Given this list of marker genes ARHGEF11, MICU2, CASTOR3P, NDUFAF8, UPP1, SNORA13, CBFA2T2, RNPS1, SLC25A6, CMC2, NXF1, IFT52, BFSP2, UQCRH, SGMS1, SLC38A2-AS1, C7orf25, SUPT7L, ADRM1, OXR1, ANP32E, GBA1, RNY3, SEC61B, STEEP1, CNN2, NDUFA11, MTERF3, NUTM1, PURPL, KCTD18, ID2-AS1, UQCC6, PDE2A-AS1, QSER1, RRM2B, SSR4P1, ELMO2, STK35, LINC00544 (NCBI Gene Id 440131), CIDECP1, SLC25A45, TWSG1, FBXO8, CDK12, ATP13A1, HSF4, TRIB3 (NCBI Gene Id 57761), MIR548K, NOP10, MST1P2, ST7-OT4, TAX1BP1, BAG5, ZNF76, DIP2C (disco interacting protein 2 homolog C), TWSG1-DT (NCBI Gene Id 102724397), SNHG25, EFNA4-EFNA3, MYNN, RFX2, PCNX2, PIK3CB (phosphatidylinositol-4,5-bisphosphate 3-kinase catalytic subunit beta), HEMK1, TEPSIN, NOTUM, LEO1, WDTC1-DT, RAD51AP1, GRHL3 (grainyhead like transcription factor 3), TNPO1, B4GAT1, SEC22B, CEBPA-DT, AKAP8L, PIM3, C2orf69, BRWD1, SEMA7A (NCBI Gene Id 8482), NAA50, POC1B-GALNT4, VWA7, ENSG00000268129, ATR, ZC3H3, SIRT1, HIF1A, EIF2AK3-DT, UBE2V1P4, C9, ZNF148, PLXDC1 (NCBI Gene Id 57125), RN7SL1, IL21R, CFLAR, ASAH1, DHPS, UBIAD1, H1-10, WWC2-AS1 (NCBI Gene Id 101928734), MOB3A, VARS1, SPATA4, TPGS2, ENSG00000187951, RNU6-1013P, STK25, ARHGAP17, SPG7 (SPG7 matrix AAA peptidase subunit, paraplegin), ABHD16A, PMVK, ENSG00000275765, VTI1A, BARHL1, NXT2, AHDC1, CD8A, ACAP3, SNHG29, ANKRD31, EIF3F (eukaryotic translation initiation factor 3 subunit F), MIR3613, RNASEK-C17orf49, NOTCH2NLA, BCL6, PIEZO1, KIF26B, MYO15B, MIR3189, CALM3, CELF1, LTBP3, IFT27, LPCAT3, SLC35F2, GSDMD, DCTN4, TUBB2A, ZC2HC1C, MTBP, HIP1, MGAT1, DCUN1D2, ARID5A, CHST12, KLHDC10, CTNNB1, ELF1, TEX2, TRIM32, MAPK6, ERCC1, PLEKHG5, ITFG1-AS1, PYGO2-AS1, PIH1D2, LZTFL1, ZNF609, SSH1, PEX13, RGS1, DNAH14, FBXO44, EIF2S3, ARPC4-TTLL3, TYW5, NUDT3, SLC9A6, RPL7AP60, ZNF689, IQUB, CBY1, GAREM1, ANKRD36, KPTN, ARL1, CYS1, GORASP1, FLCN, PSMD3, TMCC1-DT, IL6R-AS1, TBCK, NR1D2, C19orf53, AHCTF1, ABHD2, WASF2, STIM2, PTCD1, PXK, MOB4, MRPL13, RAD9A, RLIM, FBXL13, RFX1, ENSG00000254006, STIM2-AS1, TFDP1, FKBP5, SNHG17, LSG1, MIR548AW, NYAP1, POP4, CENPN, ZNF77, TSKU, MTCH1, BRIX1, TK2, HMGB1, EXOC3L1, PKN3, CA11, MADD, PHLPP2, BTG2-DT, SLC25A46, RRAS2, AIMP1, MPLKIP (M-phase specific PLK1 interacting protein), ZNF891, SF3A3, PPM1A, EARS2, RN7SKP127, DCLRE1A, COMMD6, SYNE2, EI24, TLR5, SDF4, MED13, TEX10 (NCBI Gene Id 54881), PPFIA3, AP3M2, NUP153-AS1 (NCBI Gene Id 105374952), LGALS3BP, RNF213 (ring finger protein 213), NECAB3, HOOK2, MIR4435-2HG, GNB1-DT, PIGZ, ENSG00000255367, INAVA, FRG1-DT, TMEM121, RELT, CPEB4, ZC2HC1A, TMA16, EGLN3, RPL41, THUMPD3-AS1, XKR9, CD55, ZNF165, SNORA26, LRRFIP1P1, CDON, IMMP1LP1, TNFRSF1B, NMUR1, ATRIP, DOC2A, ZFP64, ARF4P2, CENPJ, CENPS-CORT, THAP4, XYLB, TCHP (trichoplein keratin filament binding), NBPF15 (NCBI Gene Id 728936), TPRN, FLI1, ZNF513, NDUFS3, KCNT1, HSD17B14 (hydroxysteroid 17-beta dehydrogenase 14), OSBPL9, VPS52, FAM241B, PHF19, GPNMB, HDAC2, PRMT3, RIN3, RRAGC, CGB7, GMDS, DNM2, IL13RA1, BAZ1B, PIM1, LINC02168, RBBP5, CDKL3, DNAAF10, LINC02918, MAML3, PSIP1 (PC4 and SRSF1 interacting protein 1), TPM1, NBPF25P, LRP12, C19orf25, TMPO-AS1, ARMH3, IL9R, MYL12-AS1, JMY (junction mediating and regulatory protein, p53 cofactor), TRIM13, KLF13, TRPC4AP, GCNT1, CAMK2D, PDP1, SMYD2 (SET and MYND domain containing 2), ISLR2, C6orf62, WDR36, NBPF9, PAXIP1, POGK, CEP128, RBM48, RUSC2, VNN2, PAFAH1B1, PRPSAP1, ERI3, AP4M1, PI4KA, PPEF1, RHBDF2, SMARCD2, MIR4674, TRIP13, SLCO4A1-AS2, C2orf42, SEC24B, MACROH2A1, MAP3K4, TPBG, MEF2A, RNF32, TJP3, TFAP2A, ACTR3, C12orf42, ENSG00000267448, PRKCI, SUMO3, FBXO34-AS1, PET100, CPLANE2, ANKRD16 (NCBI Gene Id 54522), PPP1R9B, SARAF, LINC00431, TMBIM1, DUSP16, REXO4, BAIAP2L1, CNOT10, TMEM91, CCT3, SCRIB, MIR4645, SPATS2, SNORD48, ZNF786, RPL35A, SPATA17, RPL21, RCC1L, CEP44, TRGV6, TNIP2, LINC01348, TMCC1, LINC02363, ANKRD46, ARSB, HAUS8 (HAUS augmin like complex subunit 8), ZNF580, ST7, EIF4A2, SURF4, FRG1, FABP5P5, ALG9-IT1, CPT1B (carnitine palmitoyltransferase 1B), DANCR, KDM7A-DT, HYCC2, AP2A2 (adaptor related protein complex 2 subunit alpha 2), CLN6, ARHGAP45, BCL2L13, NEMP2, UBE2I (NCBI Gene Id 7329), TNRC6A, DESI1, NIF3L1, MSL3 (MSL complex subunit 3), EPS15, ZNF639, TET3, NSG2, BHLHE40-AS1, SAMD11, NECTIN1-DT, SMARCAD1-DT, ARHGAP22, RNU12, NR2F6, CDK5R1, ELK4, TRIM44, ARID5B, XXYLT1, LRPPRC, GZF1, FAM117A, WARS2-AS1, GPR132, SPIRE2, ATL1, ZFAND3-DT, IVD, DLC1, TARS3, IKZF4, CCDC85A, VPS51, MRPS23, CLPP, MLEC, ODF2, BBC3, BAZ2A, PPM1H, RAP2A, DPY19L1, ATP8A1, PARP1 (NCBI Gene Id 142), ZNF775, ATG101, PAXBP1, ADAM10, SRF, CENPK, OXR1-AS1, ANKRD12, LINC00963, NOTCH1, MIR29B2CHG, PTMA, CFAP97, RNF11, KBTBD2, C11orf68, MIR7-3HG, ZNF697, SPCS2, PTCD3, C6orf226, ATG13, ADNP, LINC01521, MTPAP, CPSF2, ITIH1, ENSG00000275635, COX20P2, SAE1, RAD1, RSAD1, EXOC2, HERPUD2-AS1, ANKMY2 (NCBI Gene Id 96008), DHRSX, CHMP6, LMNB2, CRACR2B, SEC31A, SLC29A1, FOXK2, CSNK2A1, ENO3, FBXO24, SEMA6A, POLR2A, PPP6C, CENPF, PRKCH, PWWP2A, ATF6, RHBDF1, ISG20, MRPL54, CD37, HSDL1, CGB2, NUP85, PEX1, MIPOL1, SMAD3, TMEM198, NDUFA5P11, PPIL3, KBTBD4, ZFX-AS1, CCDC97, MAN2A1, TLCD2, CDC45, ROBO1, ADAP2 (ArfGAP with dual PH domains 2), STAG3, IDUA, NR1H3, BAMBI, CLN3, MAPKAPK5-AS1, ZXDC, RNF135, CFLAR-AS1, CTTNBP2, FAM184A, PPP3R1, MARCHF9, TBC1D8, TRIM11, PXT1, SNHG7, LMNA, LNCOC1, ACOT8, PRMT5-DT, ILKAP, MCM9, H2AC13, CUTA, FRYL, VPS13B-DT, SIPA1L1, SLC9A1, VLDLR-AS1, ATF7IP2, PARAIL, ZNF131, SREK1IP1, KDM5A, FLT3LG, LINC01920 (NCBI Gene Id 101929260), FAM177A1 (NCBI Gene Id 283635), PCSK7, SART3, LY9, KDM5C, YJU2B, SYT7, DDX5, PAXIP1-DT, CRLF2, YPEL1, RNU6-841P, LUC7L, TRG-AS1, PTPN18, STKLD1, TRAF3IP2-AS1, IQCG, TFEB, PNO1, RPL23AP82, NAPEPLD, GBP4, MAP3K20, WASHC2C, CEP95, REPIN1, SUGCT, XPC-AS1, WNT10A (Wnt family member 10A), PRDM4, TPT1, LRP6, JAG2, SETD1A, CDC25B, FUS, RIN1, SLC2A5, RNFT1-DT, TMT1B, ANKZF1, DNAJB1, NOC4L, CAND1, SREBF1, IRF2BP2 (NCBI Gene Id 359948), RPRD1B (NCBI Gene Id 58537), PMEL, SLC1A4, UBFD1 (ubiquitin family domain containing 1), ANKLE2, DCBLD2 (discoidin, CUB and LCCL domain containing 2), LINC01962, PLEKHB2, SRRM1, TNFRSF13C, PPM1F, FSD2, BBLN, NDUFB3, SLC25A4, IBA57-DT, KEAP1, LINC01003, FAM53A, ARHGAP11B-DT, ARPP19, TRAPPC5, FBRS, PPP5D1P, FOXA1, RNF168, TPT1-AS1, MAOA, PKIA, CHMP1B, SF3A2, DCTD, WASL, HABP4, EMC4, MICOS10-NBL1, PUM3, TRAM2-AS1, DGKQ, GABARAP, TRAF2, LDC1P, PSMC3IP, DHX30, TSR3, TTN-AS1, PCBP2, PURB, PEAK1, TFRC, CCT5, ENSG00000232732 (NCBI Gene Id 101927687), STAM2, DNPH1, HSPB1, LINC01409, RAI1, VMP1, VCP, PRKAB2, CELF3, RPS15AP29, FAM111A, TMEM60, JRK, ABCA6, RFX7, FSTL3, SRA1, PLLP, RBPJ, EMC10, LINC00881, HNRNPF, ATG4B, VSIG10L, RNU2-17P, TADA3, RANBP9, PRR3P1, C2orf88 (NCBI Gene Id 84281), SNRPE, SLC26A11, JMJD1C, B4GAT1-DT (NCBI Gene Id 102724064), LINC01624, NLK, ZNF815P, TMEM259, TPTEP1, ZNF335 (zinc finger protein 335), NUP54, JPX, TMCO3, KCNC3, PSMB9, TSHZ1, GNA13, LINC02593, DOHH, LMBR1L, BLCAP, RNVU1-15, QRICH1, LINC00620, WDR83OS, SELENOS, BCAP29, SUPV3L1, DNAJB6, ARNT, ENSG00000265222, ZCCHC24, RSRC1, TECPR1, DPP9, IPO9-AS1, GNL3L, ABCB10, MEX3B, OMA1, BRD9, KCNB1, PCOLCE-AS1, RNU5D-1, ERI2, BZW2, EIF3B, CCAR2, POC1B, TTLL7, TOP2B, SKIL, LITATS1, PPP6R3, ZNF892, LL22NC03-63E9.3, INTU, MAPKAPK5, COX5A, CFAP410, TANGO2, BOD1L1, ATP6V1FP1, EPDR1, MTIF2, SH2B1, CCDC47, KMT2A, REXO1, ZNF836, FXR2, ASIC4, NCLN, ZNF10, WWOX, PABPN1, PIGP, CEBPA, FRA10AC1, NPTXR, KATNBL1, RNA5SP493, DEPDC1 (DEP domain containing 1), SHOX2, CD69, CCNE1, CBL, ADAM18, H3-3A-DT, GORASP2, POLR2J3, MRTFA, IVNS1ABP, TCF4, CXXC5, DAPK2, POLR2J4, SLC12A8, POLR3E, TRIM69, C1orf159, UQCRC2, PTEN, WDR6, LYPLAL1, ST6GAL1, ZMPSTE24, VARS2, MYO16, PIK3R3, AMN1, CACNA1A, ASH1L, NAB2, RPS3A (NCBI Gene Id 6189), HSPE1-MOB4, KCTD1 (NCBI Gene Id 284252), LRP3, ITGA9-AS1, TOR1AIP1, LINC00511, ISY1-RAB43, GALNT2, LIMD1-AS1, GDF15, TARS2, HMBOX1, FCHSD2, PNN, MLF1, POGZ, NSUN4, RNA5SP152, IL9RP3, NEK6, ENSG00000266313, MYO9A, HMBS, ENSG00000259755, SESN3, UST-AS2, TMEM219, NUFIP1, ANKRD9, GOLGA8A, FBXO25, TCERG1, UBE2Z, ARRDC3-AS1, KAT5, ATMIN, LPGAT1-AS1, MDC1, MIA2-AS1, ATP2C1, CXCR3, DGAT2-DT, RPL22, DDHD2, PPWD1, CENPS, TNFRSF17, LTA4H, DCAF5, DHTKD1, MIS12, SCAF8, BMF, DYRK3-AS1, DDX51, PCSK9, CMSS1, SELENOW, MRPL38, ATF6-DT, FRMD6, LINC01480, ADPRS, EPS8L2, IL16, DNAJB2, DAP3, RCAN1, CCDC59, SAR1B, SS18, SMG6, CCDC88A, PUS10, TRIM7-AS2, HINT3, IFI44L, RNF217, NDUFAF1, UCHL3, PCAT7, USP42, LPGAT1, USF1, VTRNA1-2, LINC02901, MAIP1, ZMAT1, AP2S1, MAPKAPK3, TRIB1, H2BC13, BICDL1, CHAF1A, INSIG1-DT, GLI1, SIGLEC5, KCNH1, C11orf24, USPL1, ZNF408, MICAL1, PCAT6, MDM2, PRAME, ARHGEF40, RPS26, HNRNPA2B1, TNFSF14, DYRK1A, HSPD1, BUB1, PATZ1, LSR, FNBP1P1, DNAJC6, RALGDS, PIP5K1B, CSTF2T, B3GALT4, RCE1, ZNF654, TIGD5, TG, PTPN11P3, NDUFS7, ZNF141, STX11, ZBTB20, SLC38A2, MAP4K4, ICMT-DT (NCBI Gene Id 148645), PTPDC1, GTF2H4, APBB1, C17orf75, ELL2, PIGT, NTMT1, TTC22, ARMC10, EFCAB7, GNB2, TASL, FBXO33, H2AZ1-DT, SNX8, CLEC17A (NCBI Gene Id 388512), ARL2, MAST1, PARVB, GDNF-AS1, HS6ST1, VEZT, KAT14, ACOXL-AS1, CD82, CROCCP2, CDC42BPA, RNFT2, COA1, CHASERR, SETD5, GET3, NRAV, MBOAT2, MYL12B, TCAM1P, DUT, PLEC, RNF214, GCGR, PIK3IP1, CFAP69P1, ALDH4A1, SERPINB1, CEP164, SEC16A, CCDC85C, ARFGAP1, ATF7, EEF1D, ELOVL1, DUSP1, ACYP1, CKB, SLC2A9, EIF4ENIF1, B3GALT6, ZFYVE9, PNPLA7, CREBRF, MACORIS, CENPP, TRGVB, PPP2R3B, SLC35E2B, FAM110A, ENSG00000261335, GPALPP1, GPR18, KCTD10, RN7SKP165, CREB3L3, NR2C2 (nuclear receptor subfamily 2 group C member 2), EP400, LINC00609, EPCIP-AS1, PPP1CA, ZFR, LIN7B, ASTN2, ACKR3, ANKRD11, MIR638, PRDX2, MANF, UTP18, OASL, STAG3L3 (STAG3 cohesin complex component like 3 (pseudogene)), KLHDC2, TAF15 (TATA-box binding protein associated factor 15), MADCAM1, PDPR2P, CORO1A, RAB3A, GPR146, MIR4479, ERVK13-1, TENT2, RPS27L, TRIP10, LTBP4, KCNAB2, ASPSCR1, BCKDK, KIF9, TMEM117 (NCBI Gene Id 84216), CLIC5, LAMP1, GNB1, SPOPL, PLXNB2, TENT4A, TRIP4, LRP2BP, IRAG2, PHRF1, ITSN2 (intersectin 2), TMEM37, MAP2K3, CSNK1G2, ZMPSTE24-DT, SLC25A25, TCAF1, EXOSC10, ZNF395 (NCBI Gene Id 55893), SGPL1, LINC00973, INTS9, DVL1, DRC3, RGS5 (NCBI Gene Id 8490), ACP2, YJU2, YY1AP1, CHST11, PRDM10, STPG1, AUTS2, INPP5A, THEM6, PDCD1, RCL1, CDKN2C, AATBC, DHRS12, HEXIM1, REV3L, SPRED2, VDAC1, RPS7, NAIF1, CFL1, UFSP2, NACC1, ALG8, CDIP1, FERRY3, YPEL5, TNFRSF10B, PFDN4, LRRC41, TBC1D2, GCLM, ZNRF1, RNU5B-1, UBTF, DIS3L, HIGD1AP5, SEPTIN2, ALMS1, RPL10A, RMND5A, KAT6B, LYRM1 (LYR motif containing 1), YWHABP2, RPL27 (NCBI Gene Id 6155), MND1P1, KATNB1, CTCF, PKNOX1, CDIPTOSP (NCBI Gene Id 440356), FCHO1, FRG1HP, JPT2, CLTB, MAN2A1-DT, FBH1, ELOVL6, SNORD49B, VTRNA1-1, MLF1-DT, RNF185, BZW1, NALT1, DDX59, TCF7, CPLX1, ILF3-DT, TMEM156, CHSY1, EPB41L4A-AS1, NAT10, TMEM260, PSMC3, ANG (NCBI Gene Id 283), ZNF212, MNX1-AS1, ETV2, PRC1, UBE2V2 (ubiquitin conjugating enzyme E2 V2), LYPLAL1-DT, RAB11FIP3, ZSWIM1, NHLRC2, TSKU-AS1, SPTSSA, MRPS7, H2AC14, ALG9, PPM1L-DT, TXNIP, RHOBTB3, DNAAF1, KLHDC8B, PYGO2, MEF2C, RNU1-19P, BTG2, STT3A (STT3 oligosaccharyltransferase complex catalytic subunit A), EFNA5, H4C11, ST20, TLR1, ENSG00000235978, MAF1, MIR5091, FAF1 (NCBI Gene Id 112268262), ALG10B, DDX42, MRNIP-DT, NUF2, FKBP8, TSACC, CALM2, MAD1L1, METTL25, LNCRNA-IUR, LANCL2, RAB39A, DMGDH, RPL12P28, SLC7A5P2, POLR1G, H4C5, ATP8A1-DT, ARPC4, PSTK, NKILA, CCNL1, GMDS-DT, LINC02174, ZMIZ2, RFLNA, MICOS10, FBXO34, RECQL5, MST1R, NEAT1, PELI3, PSMC2, CCDC7, TBC1D17, SLC2A8, GATAD2A, CTTN, GPR89A, PHF24, ACHE, KIAA1328, VPS37B, VTRNA1-3, PAK1IP1, PGD, UBE2A, NKAIN4, SLK, NECTIN1, SNX19, SPRING1, PADI1, ZFAND3, DNASE1, TCP11L2, UBL4A, NSMCE3, SACM1L, AHSA2P, UROS (uroporphyrinogen III synthase), NUBP1, SP2, RAI14, TH2LCRR, LGALS14, RARA, BUD13-DT, MRPL46, ZSWIM3, SPIN2B, ATP5F1B, CREG1, TSC22D3, POM121, UBE2B, TNFAIP8L1, LSP1, OBSCN-AS1, PUSL1, CBX3, RNA5SP324, RAB33A, RNVU1-26, VPS13B, AJUBA, ORAI1, C8orf82, C6orf52, AKR1B15, MBTD1, PDXDC1, TEAD1, PLEKHA1, LIN9, RERE, ARID2, H4C8, SCAND3, HTR5A, SYN1, DCUN1D3, NAPA-AS1, SPPL3, GNPTG, ZNF521, COPS8, CFAP20, NDRG1, PRDM1, MUC20-OT1, ADGRV1, ENSG00000232995, TEX9, ILF3, TCF3, LMBR1, NDUFV2-AS1, SCAT1, PTOV1, CUL1, ULK4, FBXW7, FAM168B, LINC02086, CCDC144BP, PLEKHG2, RHBDD3 (rhomboid domain containing 3), MTMR14, COPS8-DT (NCBI Gene Id 401037), RNF103-CHMP3, MTCL2, AP3B2, MIR4453HG, PTK2, ATG9A, RIPK2, MTMR12, MNT, HPN, ZNF391, LRRC71, ADORA2A, ATP5F1D (ATP synthase F1 subunit delta), TMC7, CPNE2 (copine 2), ZNF300 (zinc finger protein 300), CFAP221, FGD5-AS1, NFAT5, HDAC5, GPR108, APBA3 (NCBI Gene Id 9546), INSIG1, ZER1, NDUFB1, LMAN2, RELN, DYNLL1, HNRNPC, MYL11, HMGN2, FGD6, PLEKHG4, MPDZ, TIMM13, ENSG00000258623, PCTP, PAK1, PRMT5, LINC02028, RHPN2, EWSR1, TBC1D10B, EFNA4, ENSG00000257989, PITX1, SLX4, FAAP20, POMZP3, PDE2A, FAM21FP (NCBI Gene Id 648708), MIR3677HG, TRGV3, EVI5L, RUNX1, DCTN6-DT, SDHAP4, TBC1D4, GPAT4, NFKBIA, PARD6B, MAT2A, PPP1R37, FBXL16, MCM7 (NCBI Gene Id 4176), ADCY7, SRCIN1, PLCL2-AS1, TMEM87B, STK10, ASB6, SMURF2, BUD13, DNM1, ZBTB45 (NCBI Gene Id 84878), ARTN, RTTN, CHMP7, LINC00475, HIVEP3, ENSG00000266088 (NCBI Gene Id 105371773), SPHK1, SAMD4B, OTUD4, KRBA1, TNNT1, DNAAF3, PPP1R13L, KTN1-AS1, RNU4ATAC, NDUFAB1, PIK3AP1, SGMS1-AS1, OCEL1, DGAT2, RNASE4, DIXDC1, RWDD1, IPO9, UBA1, KRAS, DDX18, UBE3B, RNFT1, RPL37, KDM1A, RRAGB, GSTP1, PER3, GAB1, MIS18BP1, UIMC1, WASH3P, DENND4A, CFAP96, TAP1, ZFX, SAAL1, SLC35C2, LINC00938, BLTP3A, EXOC7, MTO1, BRD3OS, C3orf86P, RHBDL3, PSCA (prostate stem cell antigen), CISH, GGA3 (golgi associated, gamma adaptin ear containing, ARF binding protein 3), TRMT112, KDM4B, AHCYL2, THAP9-AS1, RTN4R, GTF2A1-AS1, GPAT4-AS1, BICD1, ICMT, TACSTD2, CYP17A1, ELL3, CBFB, THADA, FER1L4, SP1, ZNF778, VPS37D, PPM1L, RNU6-9, MCRIP2, GOLGA3, UTP3, ARL6IP5, SGO2, ENSG00000254718, WBP4, INTS5, CREM, TNFAIP3, RRAGC-DT, COA8, KMT5B, ZKSCAN2, RNU6-230P, DAO, RPS24, KHSRP, EPS15-AS1 (NCBI Gene Id 105378720), PPIA, LNC-LBCS (NCBI Gene Id 115561815), DISP3, KTN1, LARP4, SEC22A, ID2 (NCBI Gene Id 3398), RAB6A, SMARCE1, SNX12 (sorting nexin 12), DAB1, USP5, OGT, VMAC, ITGB7, DCP1B, BIRC3, ZC3H12A, SS18L1, RSL24D1P11, FCSK (fucose kinase), RNF166, RNU5B-4P, MORN1, LINC01629, RMI2, INTS10, MICAL3, VSIG10L-AS1, PHTF2, PCED1B, ATF7-NPFF, CYP51A1-AS1, MIR5194, PSMA7, SMAD3-DT, CORO6, DCUN1D4, TAP2, IL1R1, PARP12, SLC35E2A, PSEN2, WDR83, SAYSD1, DDX11L10, METTL26, IQCD, PANK3, WRNIP1, LINC02773, ARHGEF10, PTDSS1, CDK4, MIR1208, XPO7, NUMB, SHARPIN, TSC1, CWC27, TSNARE1, ZNF710, H4C4, NRF1, MIR378D2HG, PIP5KL1, ATXN2L, ZDHHC6, ZNF687, WASL-DT, SOCS2, SIGLEC14, AJUBA-DT, AQP10, TMEM160, VAT1, DLGAP1-AS1, NSMAF, KLK2, NEURL2, CNOT11, HNRNPUL1, CDKAL1, RNA5SP200, ZBTB4, NUTF2, FAM156A, IGHM, SLC25A22, RNA5SP168, GDI1, FGFR2 (NCBI Gene Id 2263), MAP7-AS1, SH3BP5, RAB30, LINC02984, MTG1 (mitochondrial ribosome associated GTPase 1), MIR6821, DNMT1, HMGN1, ZC3H6 (NCBI Gene Id 376940), XRRA1, H2AZ2-DT, SEPHS1, GIPC1, DUT-AS1, UBB, CYP20A1, UBALD2, EPC2, SEPTIN6, ATPSCKMT, OLA1, CPNE2-DT, GABPB2, ATP6V1A, PICK1, RNVU1-31, CTU2 (NCBI Gene Id 348180), POR, NKAPD1, MAPK6-DT, LYL1, MYL12A, TBL3, GPBP1, RNU5E-4P, PDXDC2P, CCNB3, DLST, VDAC2, IGF1R, H2BC14, FSD1L, FHIP2B, ZBTB21, ZNF581, RBM38, SMARCA2, RAB11A, TBC1D24 (TBC1 domain family member 24), TRAPPC10, G3BP1, APOL4, AGRN, ZDHHC2, MIR4449, ARMH4, SHB, ARHGAP1, FAM78A, CWF19L1, IBA57, C17orf99, CDC42SE1 (CDC42 small effector 1), MRPS11, GFI1B, KIF2A, CHPF, LNCTSI, EIF2D, WDTC1, CLASP1-AS1, SMG8 (SMG8 nonsense mediated mRNA decay factor), ANKRA2, NEU4, ABCC1, SAXO5, WSCD2, EIF4H, H2AX, ARID1A, DRAP1, GTF2A1, ARL5B, ENAM, HIBADH, RHOC, NDST2, PPP3CA, CTSA, C21orf91 (chromosome 21 open reading frame 91), PIP4K2B, XAB2, UTP15 (NCBI Gene Id 84135), KDM3A, RAB4B-EGLN2 (RAB4B-EGLN2 readthrough (NMD candidate)), MICOS10-DT, PCOLCE, H2AZ2, DHRS13, ARRDC3, MIR7155, ZNF821, SLC25A42, ARAF, SMC3, MIR4487, KIF13A, AK2, CBLN1, LINC01623, NFE2, RNF216, PMS2, C19orf48P, KANSL3, SMARCAD1, C3orf33, TOR1B, SMAD6, TALDO1, SPRYD4, CCNI, AKT1S1, LINC03072, PDXDC2P-NPIPB14P (NCBI Gene Id 731999), GRSF1, UACA, ALG2, MAPK8IP3, SNORA50C, NAV2, REV1, MNX1, RGS3, NUDT9, IQCH (NCBI Gene Id 64799), ATAD2, HLA-DMB, LINC02051, SBNO1, PRDX5, MRPL44 (mitochondrial ribosomal protein L44), THAP9, SEC24B-AS1, SNAP29, NFIC, PPFIBP2, RNF38, GPATCH2, PFKFB3, ENSG00000236846, NFATC1, MAPK1, RHOT2, COQ2, ZNF223, CENPN-AS1, KLF11, GARIN5A, CCNT2, NDC1, IPO13 (importin 13), SIRT3, IL4I1, LAIR1, AAGAB, ZFP3-DT, NSUN6, ADARB1 (adenosine deaminase RNA specific B1), MSL3-DT, CLCNKB (NCBI Gene Id 1188), ZNF687-AS1, UGCG, MTHFD1L, USP22, KCTD20, DYRK3, GASAL1 (NCBI Gene Id 401472), HERPUD2, ZNF282, TNC, TGM5, TAMALIN, UBE2O, MED16, EXOSC3, PDE4A, WDFY4, RBM6, RHOH, PTPA, SET, SNRNP35, CSMD1, RNU6-2 (NCBI Gene Id 103625684), LINC00240, ZNF143, AP1G1, APBA2, PIPOX, CRADD, APOBEC3D, ARID1B, PCBD2, MIR3928, DRAM1, NINJ2-AS1, MEIS2, KLLN, TCEAL1, ASAH1-AS1, DPM1, NOL8, CHCHD2P1, SMAD7, CD24, LIN54, NCOA3, EED, BRPF1, MIA2, TOM1L2, FLAD1, RPS14, NMT2, ADSS1, HARBI1, PICALM, RAB4B, GNG4, UFD1, PIK3R1 (NCBI Gene Id 5295), MAP4K5, NEMP1, CDIPT, MIR1302-3, RCOR1, RAB28, RDX, RNASEK, INO80, PRELID3A, SRSF9, FCER2, WRAP53, CLUAP1, TARDBP, CRK, H4C3, MIR4757, EXTL3, GLCCI1, RNU5A-1, ESYT1, ANKRD37, USP14, MRPL39, SRPK2, MYADM, RN7SL784P, GCN1, MIR6815, ATP6V0C, HMGA1, MGRN1, SIK2, TOP2A, AIMP2, TRAM2, FAM222A, SPIDR, RPS6KA1, CGGBP1, ZNF143-AS1, ZNF664, ISY1, KCNH1-IT1 (NCBI Gene Id 100874296), LRCH4, MEMO1, GAB2, HDGFL2, CCDC77, PSMD13, SNHG32, CEACAM7, KRT8, TRMT1, SLC4A1AP, NSD2, ARHGEF16, KLHL18, ASF1A, CXXC4-AS1, INTS1, LINC02404, PHPT1, PMEPA1, S100A11, SPOPL-DT, KDM7A, PRDM10-DT, SRFBP1, PET117, CBX4, EIF2AK3, SYT9-AS1, CDCA2, USP9X, SAXO3, ZNF84-DT, CCDC6, GPR107, TLCD4, ANKRD13A, DAB2, AKIRIN1, DDIT4, KCTD9, PRMT1, HEYL, CDCA3, HECW2, AMER1, HYAL2, ZNF84, TMEM250, FAM227A, CACNA1C-IT1, GGA2, SEPTIN5, ANKRD36C, TBC1D13 (NCBI Gene Id 54662), HDAC2-AS2, CTCF-DT, RPS18, ZNF354A, DCTN6, GRHL3-AS1, CYP51A1, ZNF488, NR6A1, CCDC92, MCM5, CCDC107, HDAC6, NFKB2, MARCHF2, DERL2, EGR2, PLEKHG1, PPFIA1, PLEKHJ1, CPSF4 (NCBI Gene Id 10898), PDXK, TLCD4-RWDD3, VDR, LINC01347, RER1, MYO9B, LDLRAD4, TIA1, COPS4, KLHDC9, POLR1A, SNORD104, NEMP2-DT, ENSG00000233230, TSC22D1, TMEM243, PDK4-AS1, GET4, MIR7-3, PLCG1, RN7SKP175, SMG1P3, U2SURP, KANSL1, AKNA, LSM12, WIPF1, CENPE, ARL2-SNX15, AMZ2P1, SLC44A1, RMRP, CDC73, LINC02642, RPS29, DNAJC2, TMEM248, AK4 (adenylate kinase 4), ESCO1, MTX2, RNF103, H4C12, RAB5B, CYTH2, BCCIP, OLFM2, SFSWAP, SNX25, ZCCHC2, ENSG00000207002, MOCS3, CCDC88B, MDK, ZNF839, ANPEP, MAP2K2, LINC00910, OTUD5, GPR141, KCNH2, SMARCD3, YTHDF2, HSPE1, FOS, LRIG1, ZNF219, MIR378A (NCBI Gene Id 494327), SIPA1, ITGB3BP, here is a description of the gene set: Human Gene Set: SKIL_TARGET_GENES species: Homo sapiens from publication Yevshin I, Sharipov R, Kolmykov S, Kondrakhin Y, Kolpakov F (PMID 30445619) Genes containing one or more binding sites for (SKIL) in their promoter regions (TSS -1000,+100 bp) as identified by GTRD version 20.06 ChIP-seq harmonization.